Given this list of marker genes GUCY1A2, GUK1, ADCY5, NDUFB7, NDUFV2, NDUFV3, ALDOA, DTYMK, NDUFA9 (NADH:ubiquinone oxidoreductase subunit A9), FAM3A, LETMD1, MT-ND4L, NDUFA5 (NADH:ubiquinone oxidoreductase subunit A5), ATP5IF1, NADK2, ADSL, ATP5MC3, ADCY3, VCP, SPHK2, UPP2, PRPS1, PRPSAP2, RFK, ATPSCKMT, ATP5MJ, ATIC, KMO, NADK, NDUFC2, MT-ND5, MT-ND2, NUDT2, NDUFB5, MT-ND4, PFAS (NCBI Gene Id 5198), IMPDH2, DNAJC30, DGUOK, ATP5MG, PINK1, NDUFA10, NME2, SLC52A3, STOML2, ADCY7 (NCBI Gene Id 113), ANTKMT, NPPB, NDUFA7, ATP5F1A, GART, ASPDH, NDUFB9, ADSS1, MT-ATP8 (mitochondrially encoded ATP synthase membrane subunit 8), TK2, RRM1, GUCA1ANB-GUCA1A, NMRK1, DHODH, TYMS, TBPL1, CAD, MAP2K1, PAICS, NDUFS3, AK8, HAAO, NDUFA12, NDUFB8, PARP1, ATP6V0C, UCK2, PRKN, TREM2, AK9, FLAD1, UCKL1, IDH2, NME4, ENO1, NDUFS7, NDUFS4, PID1, QPRT, AMPD2, DCK, NME2P1, NMNAT3, UPRT, NDUFC1, KYNU, ATP5MK, GMPS, GUCY1B1, RRM2B, SLC4A7, IL4, GUCY1A1, ATP5MGL, ATP5MF, GUCA1A, PNP (NCBI Gene Id 4860), ATP5F1B, COX11, NDUFB4, NME1, RD3, NDUFS1, PAPSS1, NME9, ADCY9, NDUFB1, SDHB, NDUFA11, UPP1, AK4, NDUFA8, DCTD, NME6, NME5, ACMSD, CTPS1, NDUFA1, NDUFB6, ATP5ME, ADCY2, UMPS, NDUFA2 (NADH:ubiquinone oxidoreductase subunit A2), NPPA (NCBI Gene Id 90230), ADCY1, NME7, TAFAZZIN, MT-ND6, VPS9D1, LIPA, NDUFA6, GUCY2C, MTHFD1, AK1, NDUFB10, NDUFS6, ATP5MC1, IDO1, AK3, APRT, PRKAG2, ATP5PF, NAPRT (nicotinate phosphoribosyltransferase), TGFB1, TMSB4X, DMAC2L, NMNAT1, NDUFS8, GUCY2D, AK5, NDUFA3, ADCY6, RRM2, ADCY4, PAPSS2, PRPSAP1, PPARA, IMPDH1, LDHC, ATP5F1C, NPPC, ADSS2, NDUFB11, CTPS2, SDHA, UCK1, ATP5F1E, PPAT, ATP5F1D, NMRK2, NDUFS5, AFMID, CMPK2, ADA, NDUFS2, NME3, AK2, KARS1, ADCY8, GUCY2F, PRPS2, MTHFD2L, ATP5F1EP2, ADCY10, MT-ND1, AMPD1, NPR1, NMNAT2, ATP5PD, IDO2, GARS1, AK7, SDHD, NDUFB2 (NCBI Gene Id 4708), NDUFAB1, SDHC, HPRT1 (hypoxanthine phosphoribosyltransferase 1), AK6, SLC25A13, ATP5MC2, MT-ND3, DUT, ADK, PRPS1L1, ME1, CMPK1, NADSYN1, NDUFB3, ATP5PO, UQCC3, NDUFV1, CDA, ATP5PB, NAMPT (nicotinamide phosphoribosyltransferase), AMPD3, MT-ATP6, NPR2, MIR675, NDUFA13, STAT3, SHMT1, here is a description of the gene set: The chemical reactions and pathways resulting in the formation of nucleotides, any nucleoside that is esterified with (ortho)phosphate or an oligophosphate at any hydroxyl group on the glycose moiety; may be mono-, di- or triphosphate; this definition includes cyclic-nucleotides (nucleoside cyclic phosphates). species: Homo sapiens Human Gene Set: GOBP_NUCLEOTIDE_BIOSYNTHETIC_PROCESS